Given this list of marker genes RREB1, SRC, ARHGEF7, CORO1B, ENPP2, VIL1, CORO1C, here is a description of the gene set: species: Homo sapiens Any process that activates or increases the frequency, rate or extent of lamellipodium morphogenesis. Human Gene Set: GOBP_POSITIVE_REGULATION_OF_LAMELLIPODIUM_MORPHOGENESIS